Given this list of marker genes SAA1, CCL23, FPR2, FPR1, FPR3, APP, ANXA1, HEBP1, here is a description of the gene set: Formyl peptide receptors bind formyl peptides and many other ligands species: Homo sapiens Human Gene Set: REACTOME_FORMYL_PEPTIDE_RECEPTORS_BIND_FORMYL_PEPTIDES_AND_MANY_OTHER_LIGANDS